Given this list of marker genes MYOM2, SLC1A5, IDH3A, RYR1, ACTC1, MYL11, TNNT2, TSC2 (TSC complex subunit 2), DUT, PDK2, CNR1, LMNB1, EML2, PPFIA4, SGCG, PPP2CB, APLNR (NCBI Gene Id 187), HADHA, DAAM2, ATP2A1, ABCC4, FST, ERCC2 (ERCC excision repair 2, TFIIH core complex helicase subunit), ATP2B4 (ATPase plasma membrane Ca2+ transporting 4), NDUFB6, EIF4A2, RFTN1, LDB3, here is a description of the gene set: from publication Dairkee SH, Seok J, Champion S, Sayeed A, Mindrinos M, Xiao W, Davis RW, Goodson WH (PMID 18381411) Human Gene Set: DAIRKEE_CANCER_PRONE_RESPONSE_E2 'Cancer prone response profile' (CPRP): genes changed in response to estradiol in epithelial cell cultures from patients at high risk of breast cancer. Breast cancer outcome is highly variable. Whether inadvertent exposure to environmental xenobiotics evokes a biological response promoting cancer aggressiveness and a higher probability of tumor recurrence remains unknown. To determine specific molecular alterations which arise in high-risk breast tissue in the presence of the ubiquitous xenoestrogen, bisphenol A (BPA), we used nonmalignant random periareolar fine-needle aspirates in a novel functional assay. Early events induced by BPA in epithelial-stromal cocultures derived from the contralateral tissue of patients with breast cancer included gene expression patterns which facilitate apoptosis evasion, endurance of microenvironmental stress, and cell cycle deregulation without a detectable increase in cell numbers. This BPA response profile was significantly associated with breast tumors characterized by high histologic grade (P < 0.001) and large tumor size (P = 0.002), resulting in decreased recurrence-free patient survival (P < 0.001). Our assays show a biological fingerprint of probable prior exposure to endocrine-disrupting agents, and suggest a scenario in which their presence in the microenvironmental milieu of high-risk breast tissue could play a deterministic role in establishing and maintaining tumor aggressiveness and poor patient outcome. species: Homo sapiens